Given this list of marker genes RAD21, AURKB, CDCA5, CCNB2, CENPK, ZWINT, HSD17B11, PHF19, SHCBP1, KIF11, HMMR, UCP2, H2AX, CALM3, MAD2L1, NUCKS1, PBK, KIF20A, HMGB2, RANGAP1, PTTG1, CDK1, TMSB15B, SMC4, TPM2, PLIN3, HP1BP3, TMPO, NEK2, ESPL1, TUBB6 (tubulin beta 6 class V), CCNA2, AURKA, KIF15, CKS1B, COX8A, LGALS1, ODF2, RUVBL2, NEURL1B, CHEK2, BUB3, ARL6IP1, DBF4, RHNO1, ECT2, LSM5 (NCBI Gene Id 95999), TRIM59, SKA3, APOLD1, PIF1, DLGAP5, GGH, CNTRL, CENPE, CKAP5, SKA2, PPP2R5C, HJURP, TRAIP, EIF4E, CCDC34, ASF1B, TMSB15A, MXD3, FBXO5, HMGB3, RFC3, CCNF, ARHGAP11A, PLK1, ACTN1, SPAG5, SKA1, G2E3, RTKN2, TRIP13, DCXR, DIAPH3, FAM83D, RHEB, ATAD5, JADE1, RBMX, LMNB1, SAPCD2, LRRCC1, CEP135, DEPDC1, MKI67, BUB1, CNIH4, MZT1, NEIL3, H2AZ2 (H2A.Z variant histone 2), BIRC5, NUF2, VDAC3, NCAPH, JPT1, MND1, CDCA2, TK1 (thymidine kinase 1), KIF22, HYLS1, LMO7, BTG3, SPC25, BUB1B, CENPW (centromere protein W), MED19, ORC6, DTYMK, KIF2C, SNRPA1, TNFAIP8L1, NDE1, PARPBP, TOP2A, MRPL51 (mitochondrial ribosomal protein L51), SGO1 (NCBI Gene Id 151648), TPX2, PRC1, CENPA, KIF20B, CKAP2, KIF4A, NRM (NCBI Gene Id 11270), CDKN2C, ASPM, CEP55, SGO2, SMTN, CDCA8, KIFC1, PIMREG, GAS2L3, C2orf69, ESCO2, NOSIP, NCAPD3, ARHGAP19, RASSF1, AAMDC, EZH2, CKS2 (CDC28 protein kinase regulatory subunit 2), GTSE1, H2AZ1, TUBB4B, PLK4, NDC80, TTK, LBR, KMT5A, NMU, KIF5B, ANP32E, FAM110A, CLIC1, KIF18B, DEPDC1B, RACGAP1, PSRC1, OIP5, RNF26, REXO5, WDR54, C21orf58, DDX39A, CENPN, TACC3, CIP2A, PRR11, VRK3, ARHGEF39, KIF14, CDCA3, PSME2, CEP70, KPNA2, EMC9, CENPF, CKAP2L, MELK, SPDL1, EEF1AKMT2, MIS18BP1, NSRP1, ASCL1 (achaete-scute family bHLH transcription factor 1), DCTN3 (NCBI Gene Id 11258), MKKS, CEP44, TUBA1C, NCAPD2, PPP2R5D, KNL1, UBE2T, NCAPG2, REEP4, RAN (NCBI Gene Id 87046), XRCC4, CDC25C, FOXM1, CDC20, TTF2, CCDC18, LDHA, POLR2D, HIRIP3, KIF23, RARRES2, GINS1, STIL, ILF2, CBR3 (NCBI Gene Id 874), RNF4, CDC25B (cell division cycle 25B), KNSTRN, POC1A, RRM2, CENPM, TUBG1, TROAP (trophinin associated protein), RPL39L, CCNB1, KIF18A, NCAPG, NUDT1, SMC2, UBE2C, UBE2S, CDKN3 (cyclin dependent kinase inhibitor 3), NUSAP1, here is a description of the gene set: studied in species Homo sapiens Human Gene Set: FAN_EMBRYONIC_CTX_NSC_2 from publication Fan X, Dong J, Zhong S, Wei Y, Wu Q, Yan L, Yong J, Sun L, Wang X, Zhao Y, Wang W, Yan J, Wang X, Qiao J, Tang F (PMID 29867213)